Given this list of marker genes Ophn1, Depdc1b, Ocrl, Dock8, Rhoj, Pik3r2, Arhgap26, Prex1, here is a description of the gene set: This event has been computationally inferred from an event that has been demonstrated in another species.<p>The inference is based on the homology mapping from PANTHER. Briefly, reactions for which all involved PhysicalEntities (in input, output and catalyst) have a mapped orthologue/paralogue (for complexes at least 75% of components must have a mapping) are inferred to the other species. part of: RHO GTPase cycle electronically inferred by orthology from the curated human pathway Reactome Pathway: RHOJ GTPase cycle studied in species Mus musculus